The following is a description of a gene set: studied in species Homo sapiens Human Gene Set: HP_EPISODIC_RESPIRATORY_DISTRESS Episodic respiratory distress, and this is the list of marker genes: VAMP1, SLC18A3, MYO9A, MT-TL1, MT-TW, SNAP25, SYT2 (NCBI Gene Id 6858), MT-ND3, MT-ND4, MT-ND1, MT-ND5, SLC5A7, MT-TK, COL13A1, CHAT, MT-ATP6, AGRN, MT-ND6, SLC25A1, MT-TV, MT-ND2